The following is a description of a gene set: studied in species Homo sapiens Genes containing one or more binding sites for (DPPA3) in their promoter regions (TSS -1000,+100 bp) as identified by GTRD version 20.06 ChIP-seq harmonization. Human Gene Set: DPPA3_TARGET_GENES from publication Yevshin I, Sharipov R, Kolmykov S, Kondrakhin Y, Kolpakov F (PMID 30445619), and this is the list of marker genes: STK32B, EML3, FAAP24, MT-TF, PDK3, MT-RNR1, STX6, WIZ, GLIPR2, CDC42SE2, RNA5S12, RIMS3, MTCO3P12, HIC1, TRBV13, SRF, CTDSP2, DNAJB4, LINC01915, ROM1, COPS8, SRRM1, TECR, CEP89, MTND5P11